Given this list of marker genes HLA-B, COL9A1, STT3A, ZNF687, HIRA, TCF3, MVK (mevalonate kinase), PTEN, HLA-DRB1, PRTN3, BLK, MLX, MEFV, CIITA, CD247, WAS, F9 (NCBI Gene Id 14071), PRKCD (NCBI Gene Id 5580), STAT4, FCGR2A, SPTA1, ACAN, FCGR2B (NCBI Gene Id 2213), APOE, HNF1B, RNU7-1, HFE, LMNA, RNASEH2C, TFR2, GDF5, NR4A2, CCR6, ASPN, PTPN2, SCARB2, IGHM, MATN3, FGFR3, SPTB, SPP1, NLRP3, LSM11, WIPF1, TLR7, GJB2, ITGAM, NOD2, PFKM, ABCG5, EXT1, VPS13A, TRPS1, IL2RA, ANK1, PTPN6, TRAPPC2, HOXD10, CCN2, SLC26A2, ANKRD55, IL23R, KLRC4, COPA, BANK1, CD79B, MYD88, SLC22A4, COL9A2, JMJD1C, HLA-DPA1, CLCNKB, TNFAIP3, COL1A1, MYH14 (NCBI Gene Id 79784), RNASEH2A, SEC24C, CFI (NCBI Gene Id 3426), EPB42, ATP7B, RREB1, IFNGR1, COL5A1, IMPDH2, PERCC1, ANKH, IGLL1, GCH1, TNIP1, IRF5, SLC40A1, LRP6, TBK1, CASP10, CTLA4, LRBA, GHR, ADAR, TLR4, DNAJB11, UFD1, NTRK1, PRG4, BTNL2, FCGR3B, EPCAM, COL5A2, AGA, IL2RB, RFX5 (NCBI Gene Id 5993), GJB6, BLNK, GBA1, TOM1, AIP, SLC12A3, NLRP12, MMP2, PIK3R1, G6PC1, GLA, IDS, DCLRE1C, CD244, HLA-DPB1, IL12A-AS1, CD79A, SAT1, TRPV4, FAS, BMP6, COL11A1, IRF4, DDRGK1, RNASEH2B, KIF22, IGHG1, KNSTRN, IL12A, COL3A1, P4HA2, MIF, EMILIN1, MECP2, CR2, RAG1, SLCO2A1, SHARPIN, TNFRSF1A, POGLUT1, COL2A1, ASAH1, FOXP3, PSTPIP1, LMX1B, SAMHD1, FASLG, IGHG2, TF (NCBI Gene Id 7018), TREX1, ADA2 (adenosine deaminase 2), IL10, TGFB3, RAG2, ARVCF, IL12B, COL11A2, POFUT1, C4B, BMP4, IGKC, ELF4, PRPS1, DNASE1L3, UBE2L3, COMP, EXT2, NFKBIL1, PHEX, RNF168, SYK, ACP5, SMAD2, XIAP, NGF, UMOD, MMP13, FBN1, AEBP1, FGF10, KIAA0319L, COMT, IRAK1, TNFRSF11B, SLC39A7, SEC61A1 (SEC61 translocon subunit alpha 1), CANT1, HPGD, F8, PSENEN, JAZF1, IFIH1, TNFSF4, THSD4, FRZB, C4A (NCBI Gene Id 720), HJV, PDCD1, UBAC2, DNASE1, CCN6, FGFR2, SLC37A4, C2orf69, UFSP2, IL6, UBA1, HPRT1, IL36RN, CAV1, KRT5, CCR1, GPR101 (NCBI Gene Id 83550), AP1S3, ZMPSTE24, C1QB, PIK3CD, HLA-C, BTK, MMP14, CLCN7, ERAP1, PSMB4, HGD, SPI1, SLC4A1, IRAK4, LYN, OCRL, LACC1, ETS1, LBR, PXK, LRRC8A, MUC1, COL9A3, TBX1, SMAD3, ABCG8, ADRA2A, GNAS, GP1BB, MTHFD1, PTPN22 (protein tyrosine phosphatase non-receptor type 22), here is a description of the gene set: Inflammation of a joint. species: Homo sapiens Arthritis Human Gene Set: HP_ARTHRITIS